The following is a description of a gene set: An endocytosis process that begins when material is taken up into plasma membrane caveolae, which then pinch off to form endocytic caveolar carriers. Mouse Gene Set: GOBP_CAVEOLIN_MEDIATED_ENDOCYTOSIS species: Mus musculus, and this is the list of marker genes: Nedd4l, Cav1, Src, Cav3, Prom2, Itsn1, Mapk3, Unc119, Pacsin2, Mlc1, Mapk1, Cln3